Given this list of marker genes Hltf, Neurog1, Gcm2, Clip2, Hmga2, Trpc4 (NCBI Gene Id 53329), Sim2, Rab1a, Ankrd1, Mybl1, Cux1, Hoxa6, Elf5, Hoxb3, Id3, Hoxb4, Nr4a2, Myf5 (NCBI Gene Id 320915), Vax1, Bnc1, Ppara, Hoxa13, Dppa2, Smad3, Ebf1, Foxc1, Mef2c, Vdr, Hnf1b, Rab25, Mef2b, Hoxa3, Hoxd12, Nfia, Six4, Neurod1, Nfil3, Hoxc9, here is a description of the gene set: Selected genes down-regulated in the TLX1 Tet On iEBHX15-4 cells (pro-erythroblasts) at 6 h time point. Mouse Gene Set: RIZ_ERYTHROID_DIFFERENTIATION_6HR studied in species Mus musculus Aberrant expression of the human homeobox-containing proto-oncogene TLX1/HOX11 inhibits hematopoietic differentiation programs in a number of murine model systems. Here, we report the establishment of a murine erythroid progenitor cell line, iEBHX1S-4, developmentally arrested by regulatable TLX1 expression. Extinction of TLX1 expression released the iEBHX1S-4 differentiation block, allowing erythropoietin-dependent acquisition of erythroid markers and hemoglobin synthesis. Coordinated activation of erythroid transcriptional networks integrated by the acetyltransferase co-activator CREB-binding protein (CBP) was suggested by bioinformatic analysis of the upstream regulatory regions of several conditionally induced iEBHX1S-4 gene sets. In accord with this notion, CBP-associated acetylation of GATA-1, an essential regulator of erythroid differentiation, increased concomitantly with TLX1 downregulation. Coimmunoprecipitation experiments and glutathione-S-transferase pull-down assays revealed that TLX1 directly binds to CBP, and confocal laser microscopy demonstrated that the two proteins partially colocalize at intranuclear sites in iEBHX1S-4 cells. Notably, the distribution of CBP in conditionally blocked iEBHX1S-4 cells partially overlapped with chromatin marked by a repressive histone methylation pattern, and downregulation of TLX1 coincided with exit of CBP from these heterochromatic regions. Thus, we propose that TLX1-mediated differentiation arrest may be achieved in part through a mechanism that involves redirection of CBP and/or its sequestration in repressive chromatin domains. from publication Riz I, Akimov SS, Eaker SS, Baxter KK, Lee HJ, Mariño-Ramírez L, Landsman D, Hawley TS, Hawley RG (PMID 17213805)